Given this list of marker genes MIR29C, ADTRP, MIR98, LAMA1, FSCN1 (NCBI Gene Id 6624), MIR24-1, RUNX1, BMP2, MIR19B1, ITGB3, STAT3, DPP4, TNFRSF1B, HAS2, TGFB1 (transforming growth factor beta 1), PDPN, RIC1, MIR29B1, MIR205, MIR145, MELTF, MIR19A, RB1, CLASP1, CFLAR, RECK, COLGALT1, NOTCH1, TNFRSF1A, CLASP2, EFEMP2, DDR1, EMILIN1, LRP1, TGFBR1, TNXB, ZNF469, CST3, TCF15, TGFBR3, AGT, COL6A1, ANGPTL7, AEBP1, MIR9-1, LAMA2, ANTXR1, TGFB2, LAMB2, NID1, FGFR4, ABL1, TIMP3, MIR195, PRDM5, AXIN2 (axin 2), MIR92A1, CARMIL2, TIE1, PPARG, MIR18A, LAMB1, FAP, IER3IP1, LAMC1, SLC2A10 (solute carrier family 2 member 10), DDR2, SOX9, MIR21, SMAD3, SMAD4, CHADL, IL6 (interleukin 6), MIR483, RGCC, MIR27B, here is a description of the gene set: Human Gene Set: GOBP_REGULATION_OF_EXTRACELLULAR_MATRIX_ORGANIZATION Any process that modulates the frequency, rate or extent of extracellular matrix organization. studied in species Homo sapiens